The following is a description of a gene set: Any process that modulates the frequency, rate or extent of a system process, a multicellular organismal process carried out by the renal system. Human Gene Set: GOBP_REGULATION_OF_RENAL_SYSTEM_PROCESS species: Homo sapiens, and this is the list of marker genes: CYBA, SPX, CORO2B, GJA5, ADIPOQ, GAS6, DRD2, EDN1, OR51E2, PTPRO, NPR1, NPPB, AGT, EMP2, CORIN, NHERF1 (NCBI Gene Id 9368), TTR, STC1, AGTR1, F2RL1, PDGFB, F2R (NCBI Gene Id 2149), INPP5K, ADORA1